The following is a description of a gene set: species: Homo sapiens Human Gene Set: GSE1925_CTRL_VS_24H_IFNG_STIM_IFNG_PRIMED_MACROPHAGE_UP IFN-gamma transcriptional responses in control and IFN-gamma primed primary human macrophages from publication Hu X, Park-Min KH, Ho HH, Ivashkiv LB (PMID 16148108) Genes up-regulated in macrophages primed by IFNG: untreated versus stimulated by IFNG for 24h., and this is the list of marker genes: ITM2B, GP5 (glycoprotein V platelet), IRS1, ITGB2, FBP1, ZNF18, UROS, DOCK7 (NCBI Gene Id 85440), CIDEA, GOSR2, CLDN1, KCND2, ORM1, OPRL1, PDE9A, LAMTOR3, CHRNA6, COMMD2, ETS2, UBL5, CNTN3, ACYP2, GJD2, NMRK1, GGT5, ATP6V1G1, FMOD, WDFY2, CLEC16A, CCNG2, CXADR, SRCAP, SLC5A1, PIGK, ACYP1, SLC1A6 (solute carrier family 1 member 6), NECAP1, REEP1, CASP6, MMUT, LMX1B, RNF7, COX6B2, LARP4B, FAH, APC, ATP2C1, SUCLG1, CDH10, CA8, DVL2, SLC66A3, PADI4 (NCBI Gene Id 82795), ARID3A, VTI1A (vesicle transport through interaction with t-SNAREs 1A), DPP8, RMND5A, CYP3A4, ITGA6, NIPSNAP2, ZCCHC3, AK4, DPP7, LDHB, MIDN, CAPN3, PROS1, SLC39A8, BPGM, LMO4, ZNF444, CELSR1, TSC22D1, ENO2, CCS, DBN1, RWDD4, GSTK1, F2R, METTL3, SRPK2, SGCB, ZNF354A, DDX10 (NCBI Gene Id 1662), LGALS4, AGAP3, DNAAF10, SPIB, CDO1, AP3S1, WRNIP1, PSMB1, ZRANB1, EEF2K, RASGRF2, NLN, SCP2, CFAP68, LAPTM4B, NUP50, C11orf54, COMMD5, FGF9, RBM26, GAS8, LAT2, CTSV, ACP1, EVL, AUH, PTGR1, S100A13, AXIN2, TMCO1, NUP35, GNB4 (G protein subunit beta 4), FAM8A1, FOXD1, SH3BP2, PDZK1, KLHL7, CFD, TNFRSF8, ASF1B, ANKRD1, DHRS3, TNRC6A, BRD3, TSPAN12, RRAGD, ARPC3, EPS8, RBM39, HES6, GALNT11, UBE2B, FAM216A, CCNDBP1, TNP1, ITGB1BP1, GZMK, ST8SIA1, RELL1, GLRX, BEX4, CST3, IQGAP1, LETM1, MRPL46, PSMC3IP, CXCR4, DMP1, NCAM1, PRDX4 (peroxiredoxin 4), HARS1, MBNL1, SERPINF2, GNG10, SMIM14, RTN4, UBA5, MAP3K12, GADD45A, C9orf85, ZNF808, RIMKLB, SBF2, VCAN, TMEM59, MARCHF5, ARX, WLS, SCAF8, HOXA7, HAL, CRK, PNRC1 (proline rich nuclear receptor coactivator 1), NR6A1, WDR83OS, ACP3, DDIT4, JTB, CNGA1, ADPRM, PCK1, TLR6, TMEM134, LGR5, SBDS, VLDLR, PTTG1, UBALD2, DPP4, TMEM230, NGRN, CD4, EMP1, INSIG1, CD3G